The following is a description of a gene set: Myopic astigmatism Human Gene Set: HP_MYOPIC_ASTIGMATISM A condition where one or both of the two principal meridians focus in the front of the retina when the eye is at rest. species: Homo sapiens, and this is the list of marker genes: CNGA3, MAPK8IP3, KIF11, ARPC4, BLOC1S3 (NCBI Gene Id 388552), COL1A2, VARS1, TFE3